Given this list of marker genes LHX1, BMP4, PAX8, WT1, PKD2, here is a description of the gene set: studied in species Homo sapiens Human Gene Set: GOBP_METANEPHRIC_S_SHAPED_BODY_MORPHOGENESIS The process in which the metanephric S-shaped body is generated and organized. The metanephric S-shaped body is the successor of the metanephric comma-shaped body that contributes to the morphogenesis of a nephron in the metanephros.